The following is a description of a gene set: Mouse Gene Set: GOBP_POSITIVE_REGULATION_OF_LIPID_BIOSYNTHETIC_PROCESS studied in species Mus musculus Any process that activates or increases the frequency, rate or extent of the chemical reactions and pathways resulting in the formation of lipids., and this is the list of marker genes: Apoe, Igf1, Slc27a1, Cyp7a1, Nr1d1, Sirt4, Pcx, Rab38, Rdh10, Abcd2, Dgat2, Tnf, Il1b, Qki, Mbtps2, Mtor, Mfsd2a, Dgat1, Pla2g6, Cyp17a1, Dbi, Apoc2, Htr2b, Abhd6, Wnt4, Agt, Erbb4, Kat2b (K(lysine) acetyltransferase 2B), Mid1ip1, Hnf4a, Gh, Apoa5, Mlst8, Stard4, Rdh19, Sphk2, Rdh16f2, Adora2b, Smpd3, Htr2a, Plin5, Pla2g3, Acsl3 (NCBI Gene Id 96921), Apoc3, Npy1r, Rdh1, Scp2, Srebf2, Capn2, Zbtb20, Prkaca, Sec14l2, Abcd1, Htr2c, Apoc2l, Mapk1, Ccdc3, Anxa1, Prkcd, Mlx, Paqr3, Ppara, Gpld1 (NCBI Gene Id 77224), Sirt3, Adgrf5, Avpr1a (NCBI Gene Id 54140), Chp1, Scarb1, Kat5, Ldlr, Enpp7, Cnep1r1, Por, Mlxipl, Slc45a3, Nr5a2, Ctdnep1, Pck1 (phosphoenolpyruvate carboxykinase 1, cytosolic), Tcf7l2, Cd74, Avp, Zfp750, Fabp3, Rgn, Elovl5, Nr1h4, Pla2g4a, Ppargc1a, Ifng, Sorbs1, Rptor, Gnai1, Mapk9, Fdps, Fgf1, Gpam, Abcg1, Star, Hsd17b13, Dab2, Scap, Crebl2, Creb1, Fshb, Cga, Akt1, Igf2, Rdh16 (NCBI Gene Id 19683), Il1a, Ccn1, Rdh9, Ptgs2, Acsl5, Srebf1, Nr1h3, Ogt, Nr1h2, Abcg4, Bmp6 (NCBI Gene Id 28108), Igf1r, Apoa4, Sirt2, Lpgat1